Given this list of marker genes WNT3, BCAS3, RTP1 (receptor transporter protein 1), CRIM1, DEFB4A, BPIFA3, MUC19, SIM2, PHETA1, ARHGAP45, NKX2-1, KLF12, AMOT, FAM184A, CARD6, MOBP, NRN1, PCDHB10, TSR3, C11orf91, IL18R1, EDARADD, ZNF318, NIPAL3, KLRC1, CD84, DZIP1, YPEL3, GARIN1B, IFNA6, MIR130B, NAT8B, HSD17B8, TDRD5, USH2A, ARHGEF18, ARID3B, WFDC12, TMEM74, PACS1, CIMIP7, TECPR1, BMAL1, EID2B, SNX33, KLF3, CATSPER1, OTOP1, CD96, MIR598, HIP1, SYP, AS3MT, FAM78A, PDE4D, GABARAPL2, PI15, LIX1L, USE1, EPSTI1, TMEM71, DVL3, VPREB1, GZMA, TEAD1, ABRACL (NCBI Gene Id 58527), FRMD3, F2RL2, F2R, ITGAX, TXNIP, YPEL1, SLC25A45, ZNF670, RINL, NUDT17, METTL21C, VEGFC, EZH1 (NCBI Gene Id 2145), ANTXR2, RNF166, PPM1H, RASGRP1, CNNM2, APC, ATG2A, ACSS2, NOP53, CTSA, USP3, CD2 (NCBI Gene Id 914), VAMP2, SMAD3, FAM20C, ABHD12B, TCP11L2, RHAG, PRSS45P, ACSL6, HLA-B, SFXN3 (sideroflexin 3), KIZ, CX3CR1, MAML2, MGAT4C, LRRC23, KRTAP5-1, S1PR5, ADCY7, PDCD4, DLX4, BEST2 (bestrophin 2), ZC3H6, SYNE1, CD247, GRK1, PRR23B, CXCR6, CROT, ARF6, GPRC5D, DNMT3L, RNF167, CCNI, NCKAP1, GIMAP3P, SLC6A5, RSKR, MAFG (NCBI Gene Id 84797), SH2B1, RAP2B, FBXO32, RAP2A, FAM117A, KCNJ8, SPN, TOR4A, CD226, SPAG6, HID1, KLHL14, RHD, BTG1, UTS2B, here is a description of the gene set: Genes down-regulated in induced T reg cultured with IL2: wildtype versus non-functional FOXP3. from publication Haribhai D, Lin W, Edwards B, Ziegelbauer J, Salzman NH, Carlson MR, Li SH, Simpson PM, Chatila TA, Williams CB (PMID 19265124) The gene expression profile of peripheral Foxp3+ natural regulatory T cells isolated from Foxp3/EGFP bicistronic mice was compared to that of in vitro-induced regulatory T cells and to CD4+ conventional (Foxp3-) T cells. The role of the regulatory T cell transcription factor Foxp3 in shaping the transcriptosomes of natural and induced regulatory T cells was analyzed using mice expressing a mutant FOXP3-EGFP fusion protein (Foxp3deltaEGFP). We used gene expression microarrays to examine the transcriptional programs of natural and induced regulatory T cells and the function of Foxp3 in organizing the transcriptosomes of the respective cell type studied in species Homo sapiens Human Gene Set: GSE14415_INDUCED_TREG_VS_FOXP3_KO_INDUCED_TREG_IL2_CULTURE_DN